Given this list of marker genes ECEL1, GNPTAB, TRAPPC2, RECQL4, SGCA, COMP, ZC4H2, FBN1, LMNA, PKDCC, ZMPSTE24, TPM2, HGD, GNE, here is a description of the gene set: species: Homo sapiens Abnormal shoulder physiology Human Gene Set: HP_ABNORMAL_SHOULDER_PHYSIOLOGY Anopmalous function of the shoulder. The shoulder is a ball-and-socket joint that is made up of humerus, scapula and clavicle, which are connected by the sternoclavicular joint (SC), the acromioclavicular joint (AC), the glenohumeral joint (GH), and the scapulothoracic joint (ST). The GH, AC and SC joints link the upper extremity to the axial skeleton at the thorax and enable movement at the shoulder joint: flexion, extension, and rotation of the arm.